The following is a description of a gene set: Any process that modulates the activity of an enzyme. species: Mus musculus Mouse Gene Set: GOBP_REGULATION_OF_CATALYTIC_ACTIVITY, and this is the list of marker genes: Hmgcr, Rdx, Dennd1b, Tsacc, Srcin1, Ccr7, Ncstn, Camk1, Pak1, Atp13a2, Psmb8, Tlr1, Banf1, Slc8a3, Gclm, Abi1, Rack1, Ndufa4, Sfrp2 (NCBI Gene Id 99743), Nek10, Dynapl1 (dynactin associated protein like 1), Gpihbp1, Dock9, Ndel1, Prom2, Rapgef2, Mapre2, Odam (odontogenic, ameloblast asssociated), Dhfr, Ins2, Serpinb1a, Cd24a, Edn1, Src, Ksr1 (kinase suppressor of ras 1), Adra2c, Sod1, Zeb2, Amot, Rasgrp3, Il34, Rcn3, Rcc2, Bscl2 (NCBI Gene Id 67517), Ankrd54, Chrna7, Wdr59, Ppp1r12a, Slamf1, Apc (NCBI Gene Id 11789), Ube2srt, C9orf72, Cstb, Nhlrc1 (NCBI Gene Id 105193), Fzd8, Cdk5rap1, Sfrp5, Rgp1, Angptl8, Arrdc4, Dbndd2, Map2k7, Palm, Tead1, Dgki, Gmip, Mmut, Bag5, Fem1a, Ptprj, Bmi1, Serpinb9e, Fermt2, Uri1, Snx9, Spatc1l, Abl2, Dusp7, Vcp, Nrdc, Spred1, Pkia, Ptk2b, Psrc1, Tbc1d10b, Tigar, Apoa1, Ldb1, Ltf, Map2k4, Cep85, Ralgapa1, Zgpat, Cripto, Pnkp, Fcer1a, Prkcd, B3gat3, Bcl10, Dab1 (NCBI Gene Id 545665), Casp3, C1qtnf9, Cblc, Oas1b, Iqgap1, Rps7 (ribosomal protein S7), Nedd9, Epha2 (NCBI Gene Id 13836), Inca1, Cenpe, Gnal, Adcy2, Terf1, Traf2, Mef2c, Fgd4, Rpl5, Tom1l1, Cd4, Rb1, Prkn, Eif4a2 (NCBI Gene Id 13682), Chrna3, Eppin, Ric1, Mbp, Mcph1, Bcl2, Furin, Arrdc3, Sp7, Tspyl2, Rasgrf1, Cd40, Adrb2, Pla2r1 (NCBI Gene Id 18779), Gfi1, Oas1e, Stradb, Daxx, Syap1, Evi5l, Cacna1c, Cimap3, Pin1rt1, Efna5, Psenen, Fgd1, Msh3, Ppia, Prkrip1, Nbn, Eng, Rgma, Snx13, Wfdc6a, Gstp2, F2r, Tbc1d2, Jtb (NCBI Gene Id 23922), Rab3gap2, Gsk3a, Syk, Gapdhrt, Prelid1, Trex1, Rhoa, Tbc1d7, Tsc1 (NCBI Gene Id 64930), P2rx7, Pih1d1, Slamf8, Fgf18, Gprc5a, Taco1, Htr2b, Il3, Por, Nrbf2, Rab11fip2, Fxyd3, Sfn, Ulk4, Csta1, Erbb2, Taok3, Stim1, Myocd, Fgf2, Lyn, Hgs, Nqo1, Bcl6, Cd300a (NCBI Gene Id 217303), Dnajc3, Ern1, Kitl, Abr, Map2k3, Map3k13, Ntf3, Ajuba, Gadd45b, Rfk, Lyset, Errfi1, Msh6, Fgfr2, Itgb1, Hspb1, Bcr, Mapk8, Arhgap42, Antxr1, Bmp2 (bone morphogenetic protein 2), Adcy8, Rtraf, Dnaja1, Ccdc125, Wnt9b, Pot1a, Rfc2, Slc8a2, Tbc1d20, Lims1, Dusp1, Adcy1, Tmem106b, Tmbim6, Scarb2, Tns3, Fbxw7, Cav3, Skp1, Chp1, Uvrag, Tmem225, Wrn, Sez6l, Ptprb, Rad50 (NCBI Gene Id 19360), Fgf1, Gas6 (growth arrest specific 6), Gstp3, Tlr4, Dock10, Emp2, Mtor, Abl1, Setmar, Ppp1r17, Cdkn2a, Rrp1b, Crkl, Gng7, Cstdc4, Serpinb6c, Inpp5k, Gba1, Lilrb4b, Rictor, Arap1, Nus1, Chmp6, Nos3, Serpinb9, Cav2, Jmjd8, Irs2, Plxnb1, Usp6nl, Tsg101, S100a1, Stx4a, Gprc5b, Pde3a, Rhoc (ras homolog family member C), Pim1, Ppp1r3g, Ptprc, Chi3l1, Adgrv1, Rock1, Arhgap44, Guca1a, Mapk8ip1, Calca, Cdc14b, Strada, Spdya, Drd5, Sh3bp4, Tnfsf11, Map2k1, Lmo4, Ang2, Dock11, Dffa, Ddr2, Gapdh, Map4k2, Pik3cg, Spink5, Serpinb6b, Ube2i, Crb2, Cdh3 (NCBI Gene Id 12560), Xrcc6, Slc1a1, Prex1, Tab1, Mmd, Diaph3, Scrib (scribbled planar cell polarity), Dusp19 (NCBI Gene Id 96977), Garem1 (NCBI Gene Id 97932), Map4k4 (mitogen-activated protein kinase kinase kinase kinase 4), Plk1, Fcer2a, Tm9sf5, Fgd2, Cxcl13, Sirt3, Grn, Arhgap35, Agrn, Gzma, Fgfr4, Erp29, Fem1b, Gapdh-ps15, Prlr, Synpo2, Calcr, Rgs2, Mkks, Plaa, Mst1r, Tgm2, Dab2ip, Kif14 (NCBI Gene Id 52269), Cass4, Mid1ip1 (Mid1 interacting protein 1 (gastrulation specific G12-like (zebrafish))), Akt1s1 (AKT1 substrate 1), Dnm1l, Ralgapa2, Snx18, Aph1b, Socs5 (suppressor of cytokine signaling 5), Ccs, Chtop, Npnt, Arl2 (ADP-ribosylation factor-like 2), Topors, Ephb3, Ceacam1, Lmf1, Fxn (NCBI Gene Id 14297), Vegfc, Tmem132c, Ccnd2, Vldlr, Bin1, Rapgef1, Fbn1, Adar, Cast, Rhog (ras homolog family member G), Sema4d, Nup62, Myc, Slc5a3, Tnfrsf11a, Qars1, Sez6, Pkp4, Tbc1d15, Ang4, Stat3, Serpinb1b, Nr4a2, Epha3 (NCBI Gene Id 353311), Vtn (vitronectin), Dhx9, Lrp6, Ralgapb, Svbp, Ngef, Oas1d, Lepr, Evi5, Sirt5, Ppargc1b, Mapk8ip3, Mapre3, Smpd1 (NCBI Gene Id 20597), Ppm1f, Vps25, Gpr39, Ptk6 (PTK6 protein tyrosine kinase 6), Traf4, Arhgap11a, Ralbp1, Gpr137b, Rgs10, Slc4a1, Nf2, Ptpn1, Ttc8, Cln8, Lhcgr, Spink6, Jak2, Rbl1, Map3k11, Spdye4a, Tax1bp3, Szt2, Ssbp1, Plek, Azin2, Serpinb9f, Nr1h2, Ntrk1, Sash1, Mad2l1, Timp1, Cox17, Lilrb4a, Pdgfrb, Rtn4r, Zfyve28, Ccl5, Serpinb9b, Tmed2, Asxl2, Ralb, Drd4, Map3k12, Nrxn1, Btrc, Fgf23 (NCBI Gene Id 64654), Pafah1b1, Wnt11, Ecsit, Rps2, Serpine1, F2, Map2k2, Nrg1, Spry2, Tlr6, Gnb5, Rassf2, Hmgn1, Prkca, Phactr4, Ect2, Prox1, Rfc4, Serpinb9d, Ccnd1, Map3k1, Avpr1b, Nr2f2 (NCBI Gene Id 67192), Cacul1, Calm2, Midn, Serpinb9h (NCBI Gene Id 544923), Rnf180, Dtnbp1 (NCBI Gene Id 94245), Adcyap1, Agt, Cdkn2c, Atpsckmt, Irak1, Sco1, Crk, Fgr, Rap1gds1, Rpl11, Stk38, Gdnf, Vav1, Zfp36, Arhgef16, Xrcc1, Wdr41, Smcr8, Bcar3, Ccnd3, Gtpbp4, Ccl26, Hyal2, Sipa1l1 (signal-induced proliferation-associated 1 like 1), Esr1, Sod2, Spry1, Abi2, Men1, Cdc37, Ptpn2, Cdk5r2, Cacna1d, Usp44, Wnt5a, Chp2, Stub1, Zfp91, Mmd2, Ezh2, Calm3, Edn3, Pcna, Ppm1e, Dtx3l (deltex 3-like, E3 ubiquitin ligase), Dbi, Tfap4, Parp9, C1galt1c1, Lats2, Arhgef15, Mastl, Slc11a1, Timp2, Nlrc5, Dock8, Serpinb1c, Adap1, Prkg1, Pkn1, Dennd1a, Wee2, Pten, Ptx3, Cep43, Rasip1, Ccl19-ps6, Nppa, Thy1, Irgm2, Ddx3x, Csf1r, Egf, Apoa5, Serpinb6a, Tmbim1, Deptor, Adra2b, Foxj1, Epo, Pibf1, Apoc2 (NCBI Gene Id 11813), Igtp, Fzd5, Stfa2l1, Atp5if1, Paqr3, Oas3, Grhl3, Cartpt, Socs4, Lrp1, Traf6, Adipoq, Akt2, Tert, Mvp, Efna3, Met, Htt, Ptpro, Lep, Cblb, Rasgrp1, Ap3b1, Wdr24, Gstp-ps, Cd74, Rasgrp2, Map3k4, Nox4, Map3k5, Vangl2, Ppp2r3c, Map3k7, Cab39, Csf1, F2rl1, Cib1, Serpinb6d, Wwtr1, Reln, Tnfaip3, Spock3, Lars1 (leucyl-tRNA synthetase 1), Etaa1, Chtf18, Gckr, Pik3r6 (phosphoinositide-3-kinase regulatory subunit 5), Wnk4, Ntrk2, Psen1, Lrrk2, Prss22, Hras, Cstdc5, Zfp622, Pin1, Net1, Mlst8, Trpt1, Ppp2ca, Stfa2, Serpinb8, Lats1, Gla, Oas1g, Becn1, Serpinb6e, Vav3, Tcim, Capn3, Adam9, Sfrp1, Mre11a, Chordc1, Oas1a, Map2k6, Serpinb13, Xrcc5, App, Trem2, Ccl19, Gch1, Ereg, Pdcd10, Pot1b, Agtr1a, Lrch1, Mex3b, Rab3gap1, Serpinb9c, Ifng, Epha5, Rfc5, Fbxo7, Pum3, Angpt1, Psen2, Il7, Apc2, Arhgap1, Nos1, Heg1, Xrcc4, Sirt4, Rhbdf2, Plxnb3, Dynap, Hpn, Ang, Irgm1, Neurl1a (NCBI Gene Id 80633), Hipk3, Apba3, Csta3, Cdkn1b, Prkch, Tinf2 (NCBI Gene Id 28113), Itga6, Vsir, Pdgfb, Prtn3 (NCBI Gene Id 19152), Hpf1, Cdkn2d, Nfkb1, Tnfrsf4, Drd1, Ppp1r42, Rgs8, Dlg1, Apoe, Sh3bp1, Epm2aip1, Mtrr, Rgs16 (regulator of G-protein signaling 16), Cdkn1c, Drd2, Mapk14, Adam17, Kit, Gpsm1, Aida, Csta2, Prkar1a, Hexim2, Eef1a2, Arfgef1, Shb, Atp7a, Ang6, Ddrgk1, Gadd45g, Dusp22, Adarb1, Stk11, Pip5k1a, Fnta, Apoc3, Stfa1, Ccl11, Edn2, Rps3 (NCBI Gene Id 52418, ribosomal protein S3), Thbs1, Abi3, Lgals9, Pparg, Oas1c, Trib1, Adcy7, Sesn2 (sestrin 2), Cldn4, Usp17le, Fzd4, Agap2, Ripor2, Stmn1, Mrnip, Hhex, Angptl4, Slc8a1, Cln3, Prdx5, Trib2, Rgs6, Plscr1, Mtss2, Rpl23, Bag4, Dvl3, Notch1, Trib3, Tenm1, Bbln, Rbl2, Ube2l3, Nprl2, Trim27, Tiam1, Chn1, Spock1, Apcs, Unc119 (unc-119 lipid binding chaperone), Gab1, Ube2s, Cand1, Bccip, Stox1, Rap1a, Spindoc, Arhgef7, D1Pas1, Firrm, Mapt, Polg2, Tnf, Cav1, Prdx3, Cops8, Rapgef3, Acp4, Cst3, Iscu, Ubash3b, Atp2b4, Itgb1bp1, Bcas3, Nr1h3, Bves, Flt1, Rgcc, Als2, Bbs4, Ftmt, Scarb1, Arhgap24, Plxnb2, Pik3ca, Il4 (NCBI Gene Id 16189), Smyd3, Lrp8, Phb2, Ccpg1, Rsu1, Chaer1, Park7, Rap2b (RAP2B, member of RAS oncogene family), Maged1, Ptprh, Spry4, Il1b, Pla2g5, Gpr65, Arhgap6, Myo9b, Kalrn, Wnk1, Ccdc159, Apoc2l, Itgb3, Arhgef5, Adcy4, Phpt1, Rd3 (NCBI Gene Id 74023), Angptl3, Fgfr3, Adra2a, Chtf8, Gadd45a, Rfc3, Hmga2, Ccl19-ps3, Mstn, Fbxo5, Adcy3, Rgs14, Lime1, Terf2, Prkag2, Tab2, Pdgfc, Ecm1, Ip6k2, Sdhaf4, Ggnbp2, Gnaq, Ccl19-ps5, Dstyk, Axin1, Psap, Cd200, Rap2c, Cyp27b1, Kat2b, Ang5, Plec, Calm1, Guca1b, Blvra, Ins1, Smg8, Hmgb1, Tpx2, Cldn3, Dusp10, Aplp2, Dvl2, Orai1, Rap1gap (Rap1 GTPase-activating protein), Raf1, Cdc25b, Sort1, Stfa3, Fgfr1, Tgfb2, Ccn1, Cox11, Ripk3, Sphk2, Gapdhrt2, Psma3, Map3k10, Parp1, Ubxn1, Hif1a, Rabgap1, Ccl19-ps1, Ripor1, Pxn, Fem1al, Creb3, Oas1f (NCBI Gene Id 243262), Ttbk1, Ptpn6, Ccl24, Fabp4, Ormdl3, Clspn, Tirap (NCBI Gene Id 117149), Nolc1, Ager, Apoh, Nherf1, Epha4, Akap5, Mfsd8, Pdcd4, Sgsm2, Igf1, Pik3r5, Gsk3b, Nosip, Ccdc88a, Vdr, Ccny, Neil1 (NCBI Gene Id 72774), Gstp1, Arhgef19, Taf7, Rgs7, Gskip, Abcc1, Dock7, Syde1, Serpinb9g, Reck, Oxa1l, Agtr1b, Epha1 (NCBI Gene Id 70581), Pdgfa, Spink2, Notch2, Mtmr9 (NCBI Gene Id 210376), Cdkn1a, Cdk5rap3, Wars1, Rangap1, Spink1, Cdk5r1, Cst7, Large1, Tsc2, Macroh2a1, Smad7, Ptk2, Btg1, Rapgef6, Cdk5, Sez6l2, Magi3, Ntrk3, Slc27a4, Card10, Irak3, Cdkn2b, Stil, Mt3, Fzr1, Tbc1d30, Ptprt (protein tyrosine phosphatase receptor type T), Grem1, Aph1c, Ppp1r3f, Gpld1, Wnt3a, Pnlip, Cemip, Serpina5, Timp3, Mad2l2, Vav2, Plin5, Mapk3, Zc3h15, Blm, Ctsh, Aph1a, Psmd10, Insr, Dusp3, Slc37a4, Epm2a, Npm1, Limk1, Asap3 (ArfGAP with SH3 domain, ankyrin repeat and PH domain 3), Nes, Cdc20, S100a10, Acr, Serpine2, Capn1, Apoa2, Sh3bp5, Robo1, Pkib, Snca, Pabpn1, Coa8, Cdk12, Mllt1, Fetub, Mst1, Cstdc3, Msh2, Wnt4, Akt1, Ptpn22, Srgap2, Lilra5, Higd1a, Tank, Nf1, Coro1c, Ywhab, Bag2, Ldb2, Cstdc6, Dscc1, Cldn13, Setd7, Apoc1, Tcl1, Dok7, Ern2, Ripk1, Efna1, Camk2a, Uchl1, Sgsm3, Fam3c, Pde5a, Adora2b, Sirt1, Sptssb, Oas1h, Apoa4, Dgkh, Egfr, Ccar2, Arhgef10, Ccnyl1, Dnaja3, Hnrnpu, Pycard, Tmed10, Tpd52l1, Pkig (protein kinase inhibitor, gamma), Rgs1, Ccl19-ps4